The following is a description of a gene set: studied in species Mus musculus electronically inferred by orthology from the curated human pathway part of: Signaling by ALK This event has been computationally inferred from an event that has been demonstrated in another species.<p>The inference is based on the homology mapping from PANTHER. Briefly, reactions for which all involved PhysicalEntities (in input, output and catalyst) have a mapped orthologue/paralogue (for complexes at least 75% of components must have a mapping) are inferred to the other species. Reactome Pathway: MDK and PTN in ALK signaling, and this is the list of marker genes: Ptn, Alk, Mdk